Given this list of marker genes IFFO2, STRAP, NHS, RALY, MLXIP, RABIF, RAP1GDS1, LAMC1, GIPC3, ZIK1, SP5, FGF12, STK26, CSMD1, OAS2, ZNF503, RIMS2, STK33, CCDC127, ZFAND3, LAPTM5, LIMK2, HYCC1, SCARB2, ZBTB25, SLC1A4, TBL1Y, CD247, PCMTD2, TNRC6B, P4HA1, MAST4, TAFA5, HOXA5, DNAJB14, TNS3 (NCBI Gene Id 64759), SP100, here is a description of the gene set: Human Gene Set: MIR4633_3P_MIR6500_5P from publication Chen Y, Wang X (PMID 31504780) Genes predicted to be targets of miRBase v22 microRNA hsa-miR-4633-3p, hsa-miR-6500-5p in miRDB v6.0 with MirTarget v4 prediction scores > 80 (high confidence targets). species: Homo sapiens